The following is a description of a gene set: part of: Developmental Biology Myogenesis, the formation of muscle tissue, is a complex process involving steps of cell proliferation mediated by growth factor signaling, cell differentiation, reorganization of cells to form myotubes, and cell fusion. Here, one regulatory feature of this process has been annotated, the signaling cascade initiated by CDO (cell-adhesion-molecule-related/downregulated by oncogenes) and associated co-receptors.<p>CDO/Cdon is a type I transmembrane multifunctional co-receptor consisting of five immunoglobulin and three fibronectin type III (FNIII) repeats in the extracellular domain, and an intracellular domain with no identifiable motifs. It has been implicated in enhancing muscle differentiation in promyogenic cells. CDO exert its promyogenic effects as a component of multiprotein complexes that include the closely related factor Boc, the Ig superfamily receptor neogenin and its ligand netrin-3, and the adhesion molecules N- and M-cadherin. CDO modulates the Cdc42 and p38 mitogen-activated protein kinase (MAPK) pathways via a direct association with two scaffold-type proteins, JLP and Bnip-2, to regulate activities of myogenic bHLH factors and myogenic differentiation. CDO activates myogenic bHLH factors via enhanced heterodimer formation, most likely by inducing hyper-phosphorylation of E proteins. <br>Myogenic basic helix-loop-helix (bHLH) proteins are master regulatory proteins that activate the transcription of many muscle-specific genes during myogenesis. These myogenic bHLH proteins also referred to as MyoD family includes four members, MyoD, myogenin, myf5 and MRF4. These myogenic factors dimerize with E-proteins such as E12/E47, ITF-2 and HEB to form heterodimeric complexes that bind to a conserved DNA sequence known as the E box, which is present in the promoters and enhancers of most muscle-specific genes. Myocyte enhancer binding factor 2 (MEF2), which is a member of the MADS box family, also plays an important role in muscle differentiation. MEF2 activates transcription by binding to the consensus sequence, called the MEF2-binding site, which is also found in the control regions of numerous muscle-specific genes. MEF2 and myogenic bHLH proteins synergistically activate expression of muscle-specific genes via protein-protein interactions between DNA-binding domains of these heterologous classes of transcription factors. Members of the MyoD and MEF2 family of transcription factors associate combinatorially to control myoblast specification, differentiation and proliferation. species: Homo sapiens Reactome Pathway: Myogenesis, and this is the list of marker genes: MEF2C, CTNNB1, MAP2K6, CDH15, MAPK14, MYOG, MEF2A, TCF4, MAPK12, NEO1 (neogenin 1), MYF5, CDON, CDH2, BOC, MYF6, MAPK11, NTN3, TCF12, CTNNA2 (catenin alpha 2), MEF2D, MEF2B, BNIP2, SPAG9, CDC42, TCF3 (transcription factor 3), ABL1, CDH4, CTNNA1, MYOD1